Given this list of marker genes BAX, CCNE1, FST (NCBI Gene Id 10468), IL1RN, GOLGA3, AFP, TNFRSF12A, APOA4, here is a description of the gene set: Human Gene Set: FUJIWARA_PARK2_IN_LIVER_CANCER_UP Genes up-regulated in tumorous liver tissues from PARK2 knockout mice compared to the normal, non-tumorous tissue from wild type mice. from publication Fujiwara M, Marusawa H, Wang HQ, Iwai A, Ikeuchi K, Imai Y, Kataoka A, Nukina N, Takahashi R, Chiba T (PMID 18574468) species: Mus musculus The parkin was first identified as a gene implicated in autosomal recessive juvenile Parkinsonism. Deregulation of the parkin gene, however, has been observed in various human cancers, suggesting that the parkin gene may be important in tumorigenesis. To gain insight into the physiologic role of parkin, we generated parkin-/- mice lacking exon 3 of the parkin gene. We demonstrated here that parkin-/- mice had enhanced hepatocyte proliferation and developed macroscopic hepatic tumors with the characteristics of hepatocellular carcinoma. Microarray analyses revealed that parkin deficiency caused the alteration of gene expression profiles in the liver. Among them, endogenous follistatin is commonly upregulated in both nontumorous and tumorous liver tissues of parkin-deficient mice. Parkin deficiency resulted in suppression of caspase activation and rendered hepatocytes resistant to apoptosis in a follistatin-dependent manner. These results suggested that parkin deficiency caused enhanced hepatocyte proliferation and resistance to apoptosis, resulting in hepatic tumor development, partially through the upregulation of endogenous follistatin. The finding that parkin-deficient mice are susceptible to hepatocarcinogenesis provided the first evidence showing that parkin is indeed a tumor suppressor gene.